Given this list of marker genes Hspa1a, Fos, Dnaja1, Jun (jun proto-oncogene), Hspa1b, Dusp1, here is a description of the gene set: Genes negatively differentially expressed in cell type: Treg upon treatment with cytokine: IL-1Ra in mouse lymph nodes in vivo. Mouse Gene Set: CUI_TREG_IL1RA_RESPONSE_DN Cytokines mediate cell-cell communication in the immune system and represent important therapeutic targets. A myriad of studies have highlighted their central role in immune function, yet we lack a global view of the cellular responses of each immune cell type to each cytokine. To address this gap, the authors created the Immune Dictionary, a compendium of single-cell transcriptomic profiles of more than 17 immune cell types in response to each of 86 cytokines (>1,400 cytokine-cell type combinations) in mouse lymph nodes in vivo. A cytokine-centric view of the dictionary revealed that most cytokines induce highly cell-type-specific responses. For example, the inflammatory cytokine interleukin-1β induces distinct gene programmes in almost every cell type. A cell-type-centric view of the dictionary identified more than 66 cytokine-driven cellular polarization states across immune cell types, including previously uncharacterized states such as an interleukin-18-induced polyfunctional natural killer cell state. species: Mus musculus from publication Cui A, Huang T, Li S, Ma A, Pérez JL, Sander C, Keskin DB, Wu CJ, Fraenkel E, Hacohen N (PMID 38057668)